Given this list of marker genes SPACA5, LPCAT3, SNAPIN, NSF, SH3GLB1, STAM2, GSN, TMEM201, SPAST, STX4, PAFAH1B1, TARDBP, RTN1, RAB6B, VPS37D, TMPRSS12, MVB12A, HDAC3, UGCG, SEC31A, ESYT1, TBPL1, ARMH3, CHMP2B, TMEM38B, SYT2, EMP2, PRKN, EPB41L3, LEMD2, SPACA3, MAP2K1, IER3IP1, RFX2, SPACA1, CPLX2, BET1, PALS1, MYH10, TGFB2, NDRG1, CLPTM1L, BAG6, BAG5, SRGN, RNASEK, TMEM63B, EMC6, TMEM33, WDR54, GRAMD2A, BAIAP2L1, SPACA6, SPESP1, GOLPH3L, ATP6V1A, LLCFC1, GARIN1A, TOR1A, TBC1D20, DNM1, CCDC38, SERINC3, CORO1C, POLR2M, SNX9, BIN3, VPS11, TPST2, DTNBP1, MAFB, FHIP1B, VPS37B, LNPK, ABCA7, RETREG3, BANF1, CASQ1, PLK1, MYRF, CSNK1A1, SGTA, ROPN1B, MIA3, SYT11, COG1, SNX19, AP5Z1, ZPBP2, AP1S2, PARP11, AP1M1, RBSN, GOLGA8K, COG7, RAB3GAP2, MICALL1, KCNE1, EIF2AK3, SHTN1, LMNB1, ZFYVE27 (NCBI Gene Id 118813), UBE2I (ubiquitin conjugating enzyme E2 I), PEX5, LYSMD3, SPATA46, OPTN, CLCN3, TRAPPC11 (trafficking protein particle complex subunit 11), GOLPH3, CPLX1, ARV1, HPS6, MICALL2, SYNGR2, USO1, CHMP2A, ATP6V1H, MYH9, TRAPPC12, CLASP1, SCARB2, DCTN1, GARIN4, LMNB2, CERT1, UBR4, XRCC4, EXOC8, RAB29, RAB38, SPTA1, FA2H, TSG101, DES, RAB5C, TJAP1, PI4K2B, NPLOC4, FHDC1, SPINK2, GPER1, ANXA2, TLE6, GCC2, XKR6, FNBP1L, STX19, SYPL2, FBXW8, CHMP4A, PI4K2A, BIN1, RAB22A, GOLGA8H, STEEP1, VDAC2, COG3, GOLGA8M, CTDNEP1, WDR83OS, VPS4A, AKT2, XKR7, LARGE1, MFSD14A, AP1B1, UBXN2B, TMEM38A, NHERF1, NOMO1, NOX1, PFN4, MIR138-1, CAV2, UBAP1, ANO7, BLZF1, PTK2B, SNX33, UBXN2A, SYP, GOLGA8B, TLCD2, TMEM43 (transmembrane protein 43), GOLGB1, ATP6V1D, HUWE1 (HECT, UBA and WWE domain containing E3 ubiquitin protein ligase 1), A4GALT, ATP6V0C, ZNF385A, AP3B1, SEC16A, HPS5, VTI1A, YIPF5, NOMO3 (NCBI Gene Id 408050), PDCD10, CDK1, CAMSAP3, RPH3A, NOMO2, DYNC2H1, GOLGA2, SURF4, FASLG, SYT7, SERINC2, ATP6AP1, DYM, RAB1A, ARL8B, HOOK3, TRAM1, XKR9, ATP10A, ARL6IP1, TOR1AIP1, ARHGEF7, ATP2A2, CHN2, BAIAP2, YIPF7, ILK, REEP4, ATP6AP2, BHLHA15, COL6A1, STX6, ESYT2, PHETA2, STX18, TMCO1, SYNGR1, STXBP1, AP3S2, GOLGA8IP (NCBI Gene Id 283796), ESYT3, OSBP, MTSS1, TMED6, CACNA1S, SNX3, EQTN, GORASP1, GORASP2, CAMLG, RAB5IF, BNIP1, GOLGA8T (NCBI Gene Id 653075), CAMSAP2, COG4, GOLGA8A, ANXA8L1, ARL1, AP1S1, VPS4B, ARHGAP21, FLOT1, RAB33B (NCBI Gene Id 83452), TMEM95, VTI1B, CLN3, ANK3, NCLN, ATL2, COL5A1, YWHAZ, HID1, CHMP4C, DCST2, VTA1, SMPD4, VPS25, GOLGA8S, RAB3A, MYMX, TMEM9, ATL3, GRXCR1, STX5, AKT1, ACTL7A, F2R, EEA1, S100A10, ERC2, ADAM2, TOM1, DOC2B, SYNE1, EMD, SYNJ1, SPACA5B, PLK3, GLIPR1L1, TRAM1L1, CLU, TMED2, GOLGA8Q, ANKLE2, EMC7, TRIM72, PLSCR2, IZUMO1, TMF1, PTEN, PTPRN, VPS37C, TOR1AIP2, CAV3, GOLGA6D (NCBI Gene Id 653643), ATP8B1, HOOK1, LMAN1, SQSTM1, BLOC1S2, PRKCB, TMEM170A, CSRP3, AKAP8L, CHMP3, SYT1, AGFG2 (NCBI Gene Id 3268), DEGS1, ZNF501, CHMP4B, TRPC5, PACSIN1, WHAMM, EMC8, SERINC5, PLN, PLSCR1, CPLX4, SERPINE2, CRYZL2P-SEC16B, SIRT2, UBL4A, COG6, MMGT1, EMC10, RTN3, RAB27A, GRIK5, SEC61A1, REEP5, FOLR3, JAGN1, SMPD1, VMP1 (vacuole membrane protein 1), AP3S1, VPS36, RILP, HPS3, PLSCR5, PLEKHJ1, CD9, SYT5, PLEKHM2, RAB2B, CDC42, ZPBP, BROX, PLA2G3, EMC4, SOD1, SNAP23, LAPTM4B, MAP2K2, EMC1, TMED4, MYMK, GARIN1B, F2RL3, ABCD1, NUP93 (NCBI Gene Id 9688), CCDC47 (coiled-coil domain containing 47), ATG9A (NCBI Gene Id 79065), IZUMO3, ATP8B2, COLEC12, SPTBN1, SPTBN5, TIE1, IQGAP1, SYT8, EMC9, CREB1, CAV1, TLCD1, PLEKHF1, AP1S3 (NCBI Gene Id 130340), DMKN, XKR4, SLC35D3, CSNK1D, STX17, AP3M1, VPS51, GOLGA8R, BLOC1S1, MIR26A1, CHMP1B, SPTSSB, EMC2, ATR, MTSS2 (MTSS I-BAR domain containing 2), PRRT2, STX2, CCDC42, STK25, BAIAP3, BAIAP2L2, TMED1, CHMP7, CXCR4, KNL1, TRAPPC8, ZW10, MYOF, BLOC1S3, PDE4DIP, DMTN, GOLGA8N, CHMP1A, SYT4, PLEKHF2, RTN4, POC1B, LYST, CASP7, WASHC4, TRAM2, CHMP4BP1, RAB18, SNAP29, RPH3AL, IST1, SERP1, RAB43, ATP6V0B, AP3D1 (NCBI Gene Id 8943), IZUMO1R, GBF1 (NCBI Gene Id 8729), P2RX7, PLEC, SNX18, AP1G1, GAK, ATP6V0A1, SH3TC2, AKAP9, FOLR1, MVB12B, VPS37A, GOLGA6A, SLC9A8, CR1, KIFC3, TMED9, AKTIP, CLASP2, SNX10 (NCBI Gene Id 29887), PTPRC, PRX, COG8, TOR1B, TMED7, ACTL9, RAB7A, SYT13, EHD2, SPPL2C, ZFP69B, NSFL1C, DCST1, PLSCR3, HACE1, GOLGA8O, VRK1, SYT9, SLC4A1, ANO3, PIK3C3, SPAM1, WASHC5, REEP3, CC2D1A, PHETA1, OBSL1, SEC23IP, PLEKHA3, AR, PRKD1, SEC31B, DOC2A, GOLGA8DP, GET3, ATP8B4, RNF26, VAPA (VAMP associated protein A), PDCD6IP, ATP6V1F, STX1B, ANK2, TANGO2, USP8, TMEFF2, DNM2, FOLR2, FAM174B, PRKCA, TMCC1, ARFGEF1, GOLGA5, HTT, ZBED3, LYZL6, MYO18A, AGFG1, RAB5B, SERPINA5, ACRBP, ZMPSTE24, CCDC136, TMED3, OSBPL2, COG2, VPS13B, CHMP6, GOLGA6C, HPS4, CHMP5, CORO7, MAPK1, PACSIN3, VPS28, REEP2, CPLX3, MAPK15, UMOD (NCBI Gene Id 7369), VAPB, RCC1, SNAP25, CYLC1, ANO9, ASAP1, REEP1, SNF8, NEK6, STAM, HPS1, NUP155, DNAJC13, WASH3P, USP6NL, CRB1, GOLGA6B, LAMTOR1 (NCBI Gene Id 55004), C16orf92, HGS, AHNAK, ARFGEF2, TRIP11, RAB3GAP1 (NCBI Gene Id 338380), ATG9B, GET4, REEP6 (receptor accessory protein 6), RAB8A, TMEM41B, PDCL2, XKR8, FREY1, PACSIN2, DOP1B (NCBI Gene Id 9980), ANO4, CRISP1, LPIN1, USP50, RAB11A (RAB11A, member RAS oncogene family), GOLGA8CP, GET1, LRRK2, ALS2, MYO5A, WASL, ABCA1, VAMP4, TMEM127, RAB10, TMED5, NOX5, ANO6, EMC3, GOLGA8J, COG5, AQP11, SYTL4, TMED10, BIN2, DNM1L, SOX30, SEC16B (SEC16 homolog B, endoplasmic reticulum export factor), ANXA8, LMNA, ATP8B3, ANO5, RETREG1, KIAA0319L (KIAA0319 like), LYZL4, DMPK, SNAP47, RNF112, NAGLU, PRMT5, MAPK3 (mitogen-activated protein kinase 3), STX11, ATL1, YIPF4, CAVIN2, WNK1, ABCD2, AQP1, GARIN3, RETREG2, HOOK2, RAB1B, NECTIN2, RAB2A, VPS33B, RAB30, PLSCR4, USE1, DCAF17, VCPIP1, RTN2, VPS18, TMEM147, HIKESHI, EHD3, CUL7, TRDN, NEMP1, here is a description of the gene set: Human Gene Set: GOBP_ENDOMEMBRANE_SYSTEM_ORGANIZATION A process that is carried out at the cellular level which results in the assembly, arrangement of constituent parts, or disassembly of the endomembrane system. studied in species Homo sapiens